The following is a description of a gene set: species: Homo sapiens Human Gene Set: REACTOME_SYNTHESIS_OF_GDP_MANNOSE Synthesis of GDP-mannose, and this is the list of marker genes: GMPPA, PMM1, HK1, PMM2, GMPPB, MPI